The following is a description of a gene set: Mouse Gene Set: GOBP_NEURONAL_ACTION_POTENTIAL studied in species Mus musculus An action potential that occurs in a neuron., and this is the list of marker genes: Glra1, Cacna1i, Kcnma1, Myh14, Scn3a, Grik2 (NCBI Gene Id 320644), Pawr, Kcna2, Scn10a, Scn4a, P2rx7, Scn9a, Pmp22, P2rx2, Bbs10, Hcn1, Gpr88, Kcnk2, P2rx3, Chrnb4, Gpr35, Kcnk4, Kcnq2, Chrna7, Ffar3, Chrna5, Scn2a, Fgf12, Gm2990, Scn11a, Kcnc4, Scn5a, Trpa1, Scn1a, Kcnq3, Chrnb2, Scn4b (sodium channel, type IV, beta), Ank3, Mtnr1b, Fmr1, Kcna1, Gjd2, Kcnmb3, Gba1, Cntnap2 (NCBI Gene Id 66797), Sod1, Mtor, Npr2, Rapgef4, Kcnmb4 (potassium large conductance calcium-activated channel, subfamily M, beta member 4), Ifng, Gria1, Gper1, Kcnd2, P2rx1, Scn8a, Kcnmb2, Slco1b2, Chrna4, P2rx4, Gprin3, Asic5, Dcdc2a, Dpp6, Drd1, Chrna1